The following is a description of a gene set: species: Homo sapiens Reactome Pathway: Cellular Senescence Cellular senescence involves irreversible growth arrest accompanied by phenotypic changes such as enlarged morphology, reorganization of chromatin through formation of senescence-associated heterochromatic foci (SAHF), and changes in gene expression that result in secretion of a number of proteins that alter local tissue environment, known as senescence-associated secretory phenotype (SASP).<br><br>Senescence is considered to be a cancer protective mechanism and is also involved in aging. Senescent cells accumulate in aged tissues, which may be due to an increased senescence rate and/or decrease in the rate of clearance of senescent cells. In a mouse model of accelerated aging, clearance of senescent cells delays the onset of age-related phenotypes.<p>Cellular senescence can be triggered by the aberrant activation of oncogenes or loss-of-function of tumor suppressor genes, and this type of senescence is known as the oncogene-induced senescence, with RAS signaling-induced senescence being the best studied. Oxidative stress, which may or may not be caused by oncogenic RAS signaling, can also trigger senescence. Finally, the cellular senescence program can be initiated by DNA damage, which may be caused by reactive oxygen species (ROS) during oxidative stress, and by telomere shortening caused by replicative exhaustion which may be due to oncogenic signaling. The senescent phenotype was first reported by Hayflick and Moorhead in 1961, when they proposed replicative senescence as a mechanism responsible for the cessation of mitotic activity and morphological changes that occur in human somatic diploid cell strains as a consequence of serial passaging, preventing the continuous culture of untransformed cells-the Hayflick limit.<p> Secreted proteins that constitute the senescence-associated secretory phenotype (SASP), also known as the senescence messaging secretome (SMS), include inflammatory and immune-modulatory cytokines, growth factors, shed cell surface molecules and survival factors. The SASP profile is not significantly affected by the type of senescence trigger or the cell type, but the persistent DNA damage may be a deciding SASP initiator. SASP components function in an autocrine manner, reinforcing the senescent phenotype, and in the paracrine manner, where they may promote epithelial-to-mesenchymal transition (EMT) and malignancy in the nearby premalignant or malignant cells.<p>Senescent cells may remain viable for years, such as senescent melanocytes of moles and nevi, or they can be removed by phagocytic cells. The standard marker for immunohistochemical detection of senescent cells is senescence-associated beta-galactosidase (SA-beta-Gal), a lysosomal enzyme that is not required for senescence.<p>For reviews of this topic, please refer to Collado et al. 2007, Adams 2009, Kuilman et al. 2010. For a review of differential gene expression between senescent and immortalized cells, please refer to Fridman and Tainsky 2008. part of: Cellular responses to stress, and this is the list of marker genes: CBX8, H2BC13, H2AC20 (NCBI Gene Id 8338), H2AC14, MAP2K4, EP400, TNIK, RPS6KA2, AGO3, CBX2, SP1, ASF1A, H4C1, H2BC26, AGO4, ANAPC4, CBX6, CDK6, ANAPC1, TERF2, H2AC6, ID1, ANAPC5, TERF2IP, TNRC6C, UBE2C, H1-4, H2AZ2, TNRC6A, CCNE1, UBE2S, VENTX, MAPKAPK5 (NCBI Gene Id 8550), RBBP7, CDKN1B, H2AC4, H2BC4, H2AC7, RPS27A, CDC26, MAPK8, H2BC9, E2F1, MRE11, H2BC12, TINF2, ANAPC16, HIRA, H1-0, E2F3, CBX4, CABIN1 (NCBI Gene Id 26293), H2AB1, IFNB1, SCMH1, H1-5, MAP2K6, H2BC21, H3-4, CDC16, UBA52, ANAPC10, EHMT1, MAP2K7, LMNB1, H2AC18, CCNA2, NBN, MAP3K5, H2BC14, ATM, HMGA2, UBC, H3C1, PHC2, RING1, RB1, CDK2, NFKB1, CDC27 (NCBI Gene Id 996), EED, MAPKAPK2, MDM4, TNRC6B, CCNA1, MINK1 (misshapen like kinase 1), IGFBP7, TERF1, IL6, TXN, MAP2K3, STAT3, CCNE2, H1-2, H1-1, H2BC3, RPS6KA3, UBE2E1, TFDP2, E2F2, RBBP4, CDC23, BMI1, H2BC17, CDKN2C, PHC3, AGO1, IL1A, PHC1, MAPK14, MAPK3, SUZ12, ANAPC15, UBB (NCBI Gene Id 91253), MIR24-1, RELA, H2AX (H2A.X variant histone), ANAPC7, ANAPC11, FOS, CDKN2D, ETS1, H2BC1, ACD, TP53, RNF2, MDM2, ANAPC2, H2AJ, H1-3, POT1, CEBPB, H2BC11 (NCBI Gene Id 8970), MIR24-2, UBN1, HMGA1, EHMT2, TFDP1, RAD50, CDKN2B, MAPK1, MAPK9, CXCL8, H2BC12L, CDKN2A, CDKN1A, CDK4, JUN, ERF, MAPK10, KAT5, H3C15, EZH2, RPS6KA1, MOV10, H3-3A, FZR1, H2BC15 (NCBI Gene Id 8341), MAPK11, H2BC5, MAPK7, MAP4K4, KDM6B, ETS2, MAPKAPK3, UBE2D1